The following is a description of a gene set: Genes predicted to be targets of miRBase v22 microRNA mmu_miR_704 in miRDB v6.0 with MirTarget v4 prediction scores > 80 (high confidence targets). Mouse Gene Set: MIR_704 from publication Chen Y, Wang X (PMID 31504780) studied in species Mus musculus, and this is the list of marker genes: Pptc7, Zfp97, Ces2e, Zfp763, Cpne4, Sgms1, Mycbp2, Tet2, Zc3h12c, Etv5, Zfp748, Crebrf, Gjc3, Desi2, Tm2d1, Gnpnat1, Thrb, Atp11a, Wdr26, Nkrf, Ptpn2, Ankrd33b, Nmur2, Prickle2, Ap5m1, Vamp1, Oprk1, Fgfr1, Golga1, Gabbr1, Mapk8, Atf7ip2, Zfand6, Npas3, Zfp960 (zinc finger protein 960), Syncrip, Trp53bp1, Kcnh8, Tdg, Ankrd17, Map1lc3b, Kif18a, Arhgap15, Arhgap12, Adgrg2, Tpt1, Tsc1, Sirt1, Arpp19, Mex3b, Axin1, Araf, Clip4, Fmr1, Rskr, Clmp, Sema3c, Kmt2a (lysine (K)-specific methyltransferase 2A), Dennd2c, Cldn34b2